The following is a description of a gene set: studied in species Mus musculus electronically inferred by orthology from the curated human pathway part of: Neuronal System Reactome Pathway: Transmission across Electrical Synapses This event has been computationally inferred from an event that has been demonstrated in another species.<p>The inference is based on the homology mapping from PANTHER. Briefly, reactions for which all involved PhysicalEntities (in input, output and catalyst) have a mapped orthologue/paralogue (for complexes at least 75% of components must have a mapping) are inferred to the other species., and this is the list of marker genes: Panx1, Panx2, Gjd2